The following is a description of a gene set: species: Homo sapiens A molecular function that directly (via physical interaction or direct modification) activates, inhibits or otherwise modulates the activity of a neurotransmitter receptor. Modulation of activity includes changes in desensitization rate, ligand affinity, ion selectivity and pore-opening/closing. Human Gene Set: GOMF_NEUROTRANSMITTER_RECEPTOR_REGULATOR_ACTIVITY, and this is the list of marker genes: PTK2B, TMEM35A, LYPD1, SLURP2, PSCA, LY6E, SLURP1, APP, LY6H, SPDYE11, PATE4, LY6G6D, LYPD6B, LY6S, LYNX1, PATE1, CDK5, LYPD6